Given this list of marker genes H4c11, H4c1, H2ac23 (H2A clustered histone 23), H2bc9, Tmem258, H2ac6, Psmd12, Stt3b, Erlec1, Psmc4, H4c8, H2bc3, Psmc6, Ezh2, Derl3, H3c1, Psma2, Ubb, Cul1, Derl1, Psmc3, H4c9, H3c13 (H3 clustered histone 13), Psmd7, Psmc5, H2ac24, Psma6, H3c3, H2az2, H4c3, H2bc12, Ost4, H2ac4 (H2A clustered histone 4), H4c18, H2bc27, Psmb7, Spop, Psmd13, Cdk4, H2ac12, H4c17 (NCBI Gene Id 100041230), H2bc1, Mib2, H2bc11, Psmb5, H2ac20, Psmc1, H4c2, H3c2, Ccnd1, Pdcd1, Stt3a, Pdcd1lg2, H2ac19, H2ac10, B3gnt3, Csnk2b, H3c15, H4c6 (H4 clustered histone 6), H3c7, H2ac1, Psma3, H3f3a, Psma5, H2ac15, Psma1, Psmb4, Vcp, H2ac7, Psmb6, Psmd6, H3c10, Prkag3, H2ax, H4c14, H2bc13, Psmd1, Psma7, H2ac8, H4c12, H2ac13, H4c4, Rbbp4, Cd274, H2ac11 (NCBI Gene Id 319167), Tusc3, H3c4, H3c11, H3c6, Rps27a, H2bc8, H2bc7, Ddost, H2ac22, Dad1, H2bc22, Sel1l, Rbbp7, Prkag1, H2bc15, Psma4, Psmc2, H3c8, here is a description of the gene set: part of: Co-inhibition by PD-1 Reactome Pathway: Regulation of PD-L1(CD274) expression electronically inferred by orthology from the curated human pathway This event has been computationally inferred from an event that has been demonstrated in another species.<p>The inference is based on the homology mapping from PANTHER. Briefly, reactions for which all involved PhysicalEntities (in input, output and catalyst) have a mapped orthologue/paralogue (for complexes at least 75% of components must have a mapping) are inferred to the other species. studied in species Mus musculus